Given this list of marker genes GP9, COL1A1, VWF, GP1BA, COL1A2, GP1BB, GP5, here is a description of the gene set: part of: Defects of platelet adhesion to exposed collagen species: Homo sapiens Reactome Pathway: Defective binding of VWF variant to GPIb:IX:V